Given this list of marker genes OAS1, AICDA, PROX1, ISG20 (interferon stimulated exonuclease gene 20), OAS2, TRIM28, APOBEC3B, OAS3, TNF, APOBEC3G, TNIP1, SRPK1, RNASEL, INPP5K, CCL5, SLPI, APOBEC3D, BST2, APOBEC3H, OASL, RSAD2, PLSCR1, APOBEC3C (apolipoprotein B mRNA editing enzyme catalytic subunit 3C), IFIT1, APOBEC3F, ISG15, BANF1, ZC3HAV1, EIF2AK2, IFI16, ZNFX1, APOBEC3A, ILF3, FAM111A, IFIT5, IFITM3, IFITM1, IFNB1, BTBD17, SRPK2, IFITM2, IFIH1, MX1, SHFL, MAVS, IFNL3, HMGA2, LTF, TRIM6, N4BP1, here is a description of the gene set: Any process that stops, prevents, or reduces the frequency, rate or extent of viral genome replication. Human Gene Set: GOBP_NEGATIVE_REGULATION_OF_VIRAL_GENOME_REPLICATION studied in species Homo sapiens